The following is a description of a gene set: species: Homo sapiens mitochondrial fatty acid beta-oxidation of saturated fatty acids Human Gene Set: REACTOME_MITOCHONDRIAL_FATTY_ACID_BETA_OXIDATION_OF_SATURATED_FATTY_ACIDS, and this is the list of marker genes: HADH (hydroxyacyl-CoA dehydrogenase), ACSM6, ACADM, HADHA, ACADVL, ACADS, MECR, HADHB, ECHS1, ACADL, ACSM3